Given this list of marker genes MNAT1, MAGI3, ATP10A, RASGRP2, CREBRF, NELFB, HGSNAT (NCBI Gene Id 8119), ESCO1, PPM1J, GRK4, HYPK, EMC2, RNF44, PRKAR1A, AAMDC, DPCD, MRPL42, RHOG, BRD2, LRRC1, IARS2, HNRNPH1, PDSS2, OPA1, FHIP2A, LMBRD1, FBXO15, HMG20A, PPP3CA, TM6SF1, EIF3K, ANAPC10, NIPBL, PGLYRP1, BOP1, ADAM9, EBP, PHF23, PSMB4, IRAG2, FIBP, ZDHHC13, POGLUT2, RNF103, CTDNEP1, KLC1, PCGF6, MRPL45, SDHAF1, UBQLN4, DCAF15, RCCD1 (RCC1 domain containing 1), NOPCHAP1, NSUN4, TOGARAM1, OBI1, TRIP12, MTFR1L, SPATA6, GTF2F2, HOPX, TRNAU1AP, PLEKHJ1, P2RX4, KCNQ1OT1, LAIR1, PHF6, CORO1C, GIT2, IER3IP1, NRDE2, ZNF319, IGFLR1, CELSR1 (cadherin EGF LAG seven-pass G-type receptor 1), MDP1, COASY, RER1, NDUFA8, GAK, LTA, NDRG3 (NCBI Gene Id 64401), SEPHS2, NISCH, POMP, POLR1C, TPI1, PPHLN1, GLB1, HES6, WDR5, STX16, GOLM2, TCF25, TOR3A, ZC3H12D, BCL2A1, RRP36, DNAH8, MPHOSPH10, OGFOD1, GLRX3, ITCH, ARFGEF1, CNOT2, SSR3, SUN2, RSRC1, PI4KB, TSPYL4, PRP4K, RPRD2, PDE4DIP, TSPAN5 (NCBI Gene Id 10098), FPGT, ATP5F1E, TRAP1, DDX18, RFX3, DCUN1D2, EFL1, ALKBH1, TRIM39, CDK13, ARB2A, ZC3H7A, ABHD6, NRBF2, EIF2B2, NDUFAF4, NOL8, MLH1, TGIF1, FAM120B, CLUAP1, DNLZ, SF3A3, TRIM14, RPAP2, EIF2A, CASP8AP2, KRIT1, TMEM120A, AIRN, PHF2, MRPL3, ZZEF1, GSTM4, DAG1 (dystroglycan 1), CSRNP1, BCLAF1, SGSH, GLS, NFKBIE, ERAP1 (endoplasmic reticulum aminopeptidase 1), RAD1, NFATC1, LRRC59, TUBB2B, MPHOSPH8, BTF3, PIM3 (NCBI Gene Id 415116), GTPBP3, CLEC5A (C-type lectin domain containing 5A), AGPAT5, CC2D1B, C22orf39, DDX28, NDUFS4, NFKBIZ, VPS29, MBNL1, NDUFS3, KDM5B, NDUFS7, AP3B1, ING4, NELFA, LRRC8D, CPNE1, PNRC1, ACYP1, FBXW7, SIL1, TAF1C, SRF, ENOX2 (NCBI Gene Id 95974), SIRT2, FBXO11, XPO6, GSTO1, SF3B5, ASL, RALGAPA1, CRYZ, NABP1, SOCS7, TMEM70, EXT2, GYG1, STYX, here is a description of the gene set: Human Gene Set: GSE27786_CD8_TCELL_VS_ERYTHROBLAST_UP from publication Konuma T, Nakamura S, Miyagi S, Negishi M, Chiba T, Oguro H, Yuan J, Mochizuki-Kashio M, Ichikawa H, Miyoshi H, Vidal M, Iwama A (PMID 21540074) Genes up-regulated in comparison of CD8 T cells versus erythroblasts. studied in species Homo sapiens Each fraction of mouse hematopoietic cells was purified by cell sorting from bone marrow of 8-week-old C57BL/6 mice, and its gene expression was analyzed.